The following is a description of a gene set: from publication Busslinger GA, Weusten BLA, Bogte A, Begthel H, Brosens LAA, Clevers H (PMID 33691112) Human Gene Set: BUSSLINGER_DUODENAL_I_CELLS studied in species Homo sapiens, and this is the list of marker genes: SCG2, PCSK1N, RASD1, KCTD12, SCG5, BRD2, ABCB10, KCNK17, CCK (NCBI Gene Id 885), NKX2-2, PDK3, ELL2, RAP1GAP2, CPE, MLN, GC